The following is a description of a gene set: Human Gene Set: chr2p21 species: Homo sapiens, and this is the list of marker genes: RHOQ-AS1, ZFP36L2, PLEKHH2, EPAS1, SRBD1, HAAO, PRKCE-AS1, LINC01126, RN7SL414P, SIX2, LINC01914, RN7SKP66, FTOP1, C1GALT1C1L, OXER1, CAMKMT, ENSG00000226087, KCNG3, PPM1B, PDSS1P2, LINC01819, RNU6-137P, RN7SL531P, PKDCC, MSH2, LINC02583, PRKCE, RNU6-958P, MIR559, CHORDC1P1, EPCAM, SLC3A1, ABCG5, RN7SKP119, DYNC2LI1, RNU4-63P, RPS12P4, VDAC1P13, RPL12P19, EML4, RHOQ, PREPL, CRIPT, RPS13P3, LINC02898, LINC02580, COX7A2L, RPL26P15, RNU6-566P, SIX3-AS1, KRTCAP2P1, LINC01913, LINC01820, TMEM247, MCFD2, EML4-AS1, CALM2, LINC01833, SOCS5, SIX3, RNU6-1048P, BCYRN1, STPG4, PIGF, LRPPRC, ENSG00000303185, PPM1B-DT, TTC7A, ENSG00000221300, ABCG8, RPL36AP14, RN7SL455P, ATP6V1E2, MTA3, RN7SL817P, EPCAM-DT, RNU6-242P, LINC01118, LINC01121, LDHAP3, THADA, ENSG00000253515